The following is a description of a gene set: studied in species Homo sapiens To investigate the early host response triggered by three different strains of Trypanosoma cruzi at a local infection site, changes in host gene expression were monitored in a murine intradermal infection model using Affymetrix oligonucleotide arrays. Robust induction of IFN-stimulated genes (ISGs) was observed in excised skin 24 hours post-infection where the level of ISG induction was parasite strain-dependent with the least virulent strain triggering a muted IFN response. Infection of mice immunodepleted of IFNγ-producing cells or infection of IFNγ-deficient mice had minimal impact on the IFN response generated in T. cruzi infected mice. In contrast, infection of mice lacking the type I IFN receptor demonstrated that type I IFNs are largely responsible for the IFN response generated at the site of infection. These data highlight type I IFNs as important components of the innate immune response to T. cruzi the site of inoculation and their role in shaping the early transcriptional response to this pathogen. We used microarrays to detail the local host transcriptional response to intradermal T. cruzi infection in WT mice and mice depleted of NK cells, or deficient in IFN-gamma or type I IFN responses. Additionally we compared the local host-transcriptional response generated to infection with 3 different strains of Trypanosoma cruzi (Y, Brazil, and G). from publication Chessler AD, Unnikrishnan M, Bei AK, Daily JP, Burleigh BA (PMID 19201883) Genes up-regulated in skin after injection of Trypanosoma cruzi (strain Y): wildtype (129S1) versus IFNAR1 knockout. Human Gene Set: GSE13522_CTRL_VS_T_CRUZI_Y_STRAIN_INF_SKIN_IFNAR_KO_UP, and this is the list of marker genes: KLRD1, CCND1, PIK3IP1, SLC12A7, CCR7, TEC, H2BC13, ICAM2, VSIR, AFP (NCBI Gene Id 174), TMIE, NTRK3, SUPT7L, FAM78A, ATXN7L3B, CBX4 (chromobox 4), PLD4, RPL14, PCED1B, LYPD6B (LY6/PLAUR domain containing 6B), FNTB, C19orf38, ITGB3, MPEG1, CTSV, DUSP7, PPIC, FFAR2, APP, HLA-DRB1, RCBTB2 (NCBI Gene Id 1102), LMO4, GALNT6, SLC38A2, TMEM186, RASSF2, TDRP, AMIGO2, DUSP10, THNSL1 (NCBI Gene Id 79896), HS3ST3B1, CRTAM, GPR180, DNASE1L3, FCER1G, ACP5, RPS8, ACTN1, CTSH, METTL9, ARSB, GPR18, EMB, ALS2CL, XKRX, ENC1, COMMD8, ACVRL1, RGCC, THEMIS, ANKRD13A, KMO (kynurenine 3-monooxygenase), RTN4RL1, TMEM203, PXYLP1, SLC16A5, ADH1C, ATP8B4, ABHD15, ARHGAP29, UPB1, ELOVL7, GPRC5B, PADI2, FNDC10, GPR183, IKBKB, GRAMD2B, MAN2A2, EEIG1, CNGA1, STIM1, LEF1, HID1, XYLT2 (NCBI Gene Id 64132), HAVCR1, PPP2R1B, PKNOX1, SNHG8, RPA1, SUGT1, CAMKK2 (NCBI Gene Id 121657), GPD2, TMEM9B, ACVR1B, THEMIS2, DAPL1, LIPA, PDE4B, ANXA5, GALNT9, F2RL1, HEXIM1, RAMP3 (receptor activity modifying protein 3), RFLNB, SCML4, GTF2I, IKBKE, ITK, MCEMP1, FAM234B, LY86, HSD11B1, APOBR, GRK6, MBOAT1, LBP (NCBI Gene Id 3929), PITPNA, RAPGEF4, SMIM5, MREG, TSPAN14, DYRK2, IGLC7, RBM17, RUNX3, PPP2R5A, SETD4, PDE3B, TCF7, SPIB, CLEC10A, POU2AF1, LYST (NCBI Gene Id 1130), IL1RL2, APPL2, DNTT, AMPD1, AQR, IFT25, SATB1, EHD3 (NCBI Gene Id 30845), MCTP2, SLC49A4, GMFG, CDR2, RPS29, TSPYL4, WDFY4, BPNT1 (3'(2'), 5'-bisphosphate nucleotidase 1), ARL4C, TYROBP, PTGR3, SGK1, SNN, AP2B1, SCP2, ID2, RGMB, PDLIM4, DGKA, SEMA4F, KCNMB4, CNN3, SLC20A1, TANC1, VTI1B, AMZ1, EPAS1, ZNF354C, CSNK1E, LDLRAP1, TTYH3, OSTF1, HLA-DQA1, FASLG, BBS9, GRAMD1A, IL21, RNF145, LRRC75B, NAPSA, FEZ2, SPSB1, RNF167, SLPI, MSRA, PRF1 (perforin 1), TGFBR2, GPATCH4, IBTK, TGFBR3, DENND2D, PPM1H, MYO10, ALOX5AP, RANBP10, FCGRT, SIKE1 (suppressor of IKBKE 1), CD247